The following is a description of a gene set: Human Gene Set: MIR7155_5P Genes predicted to be targets of miRBase v22 microRNA hsa-miR-7155-5p in miRDB v6.0 with MirTarget v4 prediction scores > 80 (high confidence targets). species: Homo sapiens from publication Chen Y, Wang X (PMID 31504780), and this is the list of marker genes: DRG2, BCO2, DENND11, RHOA, MIP, USH1G, ZBED4 (zinc finger BED-type containing 4), WNK3, MAPK8 (NCBI Gene Id 5599), SND1, NCDN, ARFIP1, CDC42EP1, C4orf33, GRIK5, ARL10, SIDT2, EMILIN3, PA2G4, FEN1, SPRED3, ZMAT4, OSBPL1A, DSE, EPHA7, HS3ST5, KDM1B, SIRT2, TSPAN11, CELF6, CHD9, HLF, TXNIP (NCBI Gene Id 10628), THBS3, MUCL3, TLN1, S1PR2, CNIH3, SPCS1, TBC1D2B, GFAP, MNT, ARL8B, ANKRD22, MEIS1, ZZEF1, FCHSD1, ADGRG5, STX1B, FHIP2B, TTYH3, LZTS3, PKLR, DAGLA, RPS27L, AAK1, LITAF, LYRM4, SLC27A4, HMMR, SLC25A14, GPD1, ICOSLG, PADI2, SLC48A1, BRCA1, SLC34A2, CNGB1, NFKBID, SEZ6L, AMD1, GDI2, INSL3, NUBPL, PPP1CA, GLG1, ADAM10, GIPC3, ZMYND11, PAX8, LARP1, DHRS13, FAM216B, SRM, CALN1, ADARB1, SLC38A7, GPI, PRKAR2A, MARCKSL1, YY1AP1, TNFRSF14, FBXL18, CD160, BCAM, ZC2HC1A